The following is a description of a gene set: Human Gene Set: HP_ATROPHY_DEGENERATION_AFFECTING_THE_CENTRAL_NERVOUS_SYSTEM Atrophy/Degeneration affecting the central nervous system species: Homo sapiens, and this is the list of marker genes: TDP1, FKBP6, HERC1, ATP5F1E, NEUROD2, NEK1, KANK1, NFU1, TAF2, CLN6, ATP5PO (ATP synthase peripheral stalk subunit OSCP), SCN1A, ABCD4, GPKOW, SCN9A (NCBI Gene Id 93955), PGAP2, EMC1, FRMPD4, SCO2, GABBR2, METTL27, ECHS1, NOVA2, IKBKG, VPS11, CDH23, PLCB1, GABRD, GNPTAB, NDUFA11 (NCBI Gene Id 126328), POLR3K, RNU7-1 (RNA, U7 small nuclear 1), PPFIBP1, RTN2, SLC17A5, STXBP1, ATAD1, MT-ND1 (mitochondrially encoded NADH:ubiquinone oxidoreductase core subunit 1), RHOBTB2, SETX, DTYMK, NALCN, FGF12, EXOSC8, PDHA1, LHX1, SLC19A1, RMND1, DOCK7, PARS2, MED25, COQ9, POLG, CYB5A, UBA5, SUCLG1, LYST, DEGS1, PDE6D, SLC39A8, GET4, SPG7, TTC5, MOCS1, RFC2, VPS13A, PMPCA, SIGMAR1, DCDC2, OSTM1, DOCK6 (dedicator of cytokinesis 6), PCNA, TOMM40, ATP6AP2, PIGQ, YRDC, GFM2, TAF6, ZSWIM6, OPA1, COG7, NDE1 (nudE neurodevelopment protein 1), CYP27A1, WDR81, MT-CO3, GM2A, TBL2, KCNQ2, ATXN3, NFIX, STX1B, SERAC1, GAD1, TARS1, DPH5, FUCA1, BICRA, ALDH7A1, TBCK, RPS6KA3, ITPA, NDUFV1, CTCF, SLC35C1, PPP3CA, YWHAE, KARS1, KIF7, GCDH, PNKP, SLC33A1, SUMF1, DYNC1I2, CPLANE1 (NCBI Gene Id 84157), ITPR1, LIMK1, PIGT (phosphatidylinositol glycan anchor biosynthesis class T), CNPY3, NUP54, KIF26A, QARS1, ATP1A2, POMT1, BCS1L, SEPSECS, SLC39A4, GLE1, CCDC47, AGA, ERCC8, NAGA, ATN1, MVK, CTSF, GABRB2 (gamma-aminobutyric acid type A receptor subunit beta2), IRF2BPL, MRM2, LAGE3, SNCAIP, CASK, ST3GAL5, XPA, TIAM1, EHMT1, WIPI2, BTD, TRNT1, TECPR2, ADH1C, MECP2, CHAMP1, MMADHC, ACTG1, MAPT, NAXD, UFM1, GOT2, HID1, ALG3, ASAH1 (NCBI Gene Id 79795), ACTB, MARS2, GLYCTK, SORL1, EXOSC1 (NCBI Gene Id 51013), SHPK, MECR, PTDSS1, NTNG2, VPS33A, ATP13A2, ATP5F1A, CTNS, EIF4A2, MT-TT, USH1G, LMNB1, CACNA1A, GRN, ADK, NARS2, DPAGT1, ADAM22, SLC16A2, VAC14, KIF1C, SCN3A, MEF2C, MBTPS2, ELOVL4, DPM1, PIGN, AIFM1, HIC1, COQ4, MT-TL1, SLC32A1, CYLD, CYFIP2, OFD1, TBK1, VPS35, CDK19, KCNMA1, PHGDH, FOXP2, CWC27 (CWC27 spliceosome associated cyclophilin), SIK1, CFAP410, BRAF, KCNC2, VRK1, LIPT2, CCT5, ATP5F1D, GBA1, SON, DARS2, STAMBP, ATXN2, PCCB, ATP6V1A, SNCA, TBL1XR1, VPS41 (NCBI Gene Id 27072), ADGRV1, SLC5A6, NHLRC2, PUF60, PCLO, CLPB, EPG5, HNRNPA1, ALG14, MAP2K2, PMPCB, SUCLA2, PYCR2, RUSC2, TREX1 (NCBI Gene Id 82474), PFN1, ALS2, TRAF7, DHCR7, PRKDC, FUS, DPYD, C19orf12, TRAPPC11, TRMT5, PTCD3, SNF8, ACTL6B, MYO7A, UBQLN2, RFXAP, CARS2, GRID2, SLC35B2, AP4E1, GNAO1, RTEL1, PPP2R2B (NCBI Gene Id 56686), FARS2, MTHFR, RAD21, ADPRS (NCBI Gene Id 54936), NOTCH3, ERCC3, LRRK2, TCTN3, GALC, B3GLCT, VCP, NARS1, DNAJB4, REPS1, IDS, GRIA4, PIGU, MAF, PCK1, TIMM50, PAFAH1B1, TGFB1, SLC25A15, OPHN1, PDYN (prodynorphin), CASZ1, POLA1, ALG13, GRIA2, TUBGCP4, DNMT1, GNAQ, EXOSC5, FTO, SLC1A2, AP4S1, APOE, CIZ1, STAG1, COG2, VPS53, YWHAG, GRIN1, SMC3, COG4, IFT56, NMNAT1, FXN, MAP2K1, MORC2, IFIH1, NDUFV2, TBCD, NODAL, COQ2, FMR1, CACNA1I, PIGV, TMX2, SYNGAP1, ZNHIT3, AARS1, KCNA1, RAB23, POGZ, C9orf72, MAN2B1 (mannosidase alpha class 2B member 1), SNRPN, PRKAR1B, GNB1 (NCBI Gene Id 87729, G protein subunit beta 1), SLC39A14, TMEM270, L2HGDH, MT-ND4, AARS2, YME1L1, ATG7, USH1C, SMG9, TANGO2, KDM6A, TARS2, CBS, SYNE1, PUS7, PRKN, PRDX3, AHDC1, PSEN1 (presenilin 1), GTF2H5, WASHC5, CLN8, UQCRC1, PDE10A, CPSF3, CHMP2B, TPK1, POLR1A, GLUL, COASY, GABRA5, USP9X, MYO5A, PCCA, PPT1, KIDINS220, SAMHD1, LARGE1, MT-TW, NUS1, TMEM67, FDXR, CRLS1, AP3B2, PARN, APP, DNAJC3, FARSB, FADD, TYROBP (transmembrane immune signaling adaptor TYROBP), CLCN4, MT-ND5, NUP214, PQBP1, GABRG2, PUM1, ELOVL5, POLR3B, MRAP, EIF2B4, MT-CO2, MAG, GMPPB, RNASEH2A, POMT2, GTF2I, ADAT3, KIF1A, WARS2, PNPLA6, DNAJC6 (NCBI Gene Id 9829), SETBP1, FGFR3, EXOC7, ATPAF2, GRIN2A, MED17, TRAPPC9 (trafficking protein particle complex subunit 9), NRROS, NGLY1, NDUFA9, SLC25A46, PLA2G6, WWOX, GEMIN4, MT-ATP6, TBC1D24, NUTM2B-AS1, COL18A1, WHRN, ASNS (asparagine synthetase (glutamine-hydrolyzing)), ATP5MK, CLN5, MT-TF, TSEN15, TPP1, TRAPPC6B, PANK2, COX4I1, AP4B1, TMEM147, SLITRK2, AUH, FKRP, SPEN, EXOSC9, GON7, KCNQ5, UGP2, TREM2, CDKL5, COG1, ERCC1, NTRK2, TBP, SMN1, DHX30, EXOC8, SLC38A3 (NCBI Gene Id 10991), LRP12, DNAJC5, MMACHC, VPS16, HEXB, ADAR, PRNP, VPS4A, ACY1, PODXL, GLB1, PIGL, EXOSC2 (exosome component 2), NACC1, PEX1, OCA2, SKI, PCYT2, TTC19, PRDM16, TXN2, COG6 (component of oligomeric golgi complex 6), NAXE, STX1A, PCDH15, FA2H, SYT2, DHDDS, HTRA1, PDHX, FAR1, MYT1L, RNU4ATAC, TERT, CYB5R3, TARDBP, ABCD1, NUP133, ZNF668, LYRM7, UBAP1, MT-TH, TOE1 (target of EGR1, exonuclease), STUB1, DNM1L, MDH2, GABRA1, ATL1, NDUFAF5, MINPP1, HTT, ANG, DNM1, CHCHD10, PEX19, SOD1, EIF4G1, NDUFB8, SNX14, SPTBN1, TIMM8A, NAA10, DLAT, EMX2, KCNA2, JPH3, NBN (NCBI Gene Id 4683), GLT8D1, CNTNAP1, ATP1A3, PON3, PLAA, HNRNPA2B1, FH, PHACTR1, ERCC6, FTH1, OPTN (optineurin), HRAS, OTUD6B, WNK3, PCDHGC4 (protocadherin gamma subfamily C, 4), RBL2, KCNB1, FGF13 (fibroblast growth factor 13), AFG2A, OCLN, SMARCC2, PITRM1, NUP62, UNC80, PNPO, NEFL, ESPN, RERE, BRAT1, PIGS, NCF1, PON1, PLPBP, GBA2, ATXN7, SOX10, TSEN54, HSD17B10, BSCL2, IBA57, SLC12A5, AMPD2, SPG21, PIGP, OSGEP, B4GALNT1, TMEM106B, KCNAB2, NADK2, NAE1 (NCBI Gene Id 8883), CPLX1, ZFX, FBLN1, TRAPPC12, NDN, RNF113A, HDAC4, PRPH, CTDP1, HSD17B4, CNKSR2, RBM28, WDR73, ALG1 (NCBI Gene Id 56052), HSPG2, ALG11, SERPINI1, PRDX1, NDUFS2, TRRAP, UBA1, TINF2, GFAP, MT-ND6, RNU4-2, UCHL1, DIAPH1, PCDH19, GFM1 (NCBI Gene Id 85476), TK2, BRD4, TRIM8, SMN2, PRRT2, UBE3A, MPDU1, HEPACAM, NECAP1, SNORD118, ASPA, AP4M1, SZT2, GTF2E2, MOCS2, ESAM, CAD, H3-3A, MMP23B, RNASEH1, COX16, PIGA, ALG8, NIPBL (NCBI Gene Id 25836), FRRS1L, PRKCZ, NIPA1, YIF1B (Yip1 interacting factor homolog B, membrane trafficking protein), SLC25A22, DALRD3, SACS, CAPRIN1, OTUD5, ERCC5 (ERCC excision repair 5, endonuclease), SCN2A, SMC1A, AXIN1, DNAJC30, MTR, CAMTA1, EPM2A, HTRA2, NDUFS1 (NADH:ubiquinone oxidoreductase core subunit S1), ABHD5, WDR45, ATP6V0A1, FTL, POLG2, NANS, FLI1, SLC2A1, NDP, DMXL2, DCTN1, GRIN2D, GUF1, TRAK1, PSAP, AIMP1, ACO2 (aconitase 2), COX8A, KMT2D, CCNF, EPRS1, VAPB, BMP4, NHLRC1, KCNT1, CELF2, AP1B1, CPA6, ZNF592, KPNA3, PIGG, PLK4, ROGDI, UNC13A, CLN3, SLC9A6, SQSTM1, CARS1 (cysteinyl-tRNA synthetase 1), SNAPC4, PUS3, DNAJC13, ADARB1, SHQ1, TPI1, PACS2, SCN8A, BUB1, CEP126, RNU12, AFF3, SPG11, GUSB, TPRKB, AP1S2, CIB2, UBE4B, BCAS3, AP3D1, ARX, INTS11, LSM11, DAO, ALDH18A1, DHFR, TUBGCP6, TRIT1, CACNA1B, NEXMIF, UBTF, ALG9, ADA2, ATRX (NCBI Gene Id 6475), PEX7, NEFH, TMCO1, MT-TS2, SCO1, DNAJC19, SATB1, EXOSC3, EEF1A2, FOLR1, KIF5A, GTF2IRD2, ERCC4, MOGS, MTRR, IDUA, AIMP2, ZNF335, MAPK8IP3, FBXL4, ATXN1, NR4A2, CPT1C, FBXO28, NDUFA2, RNASEH2B, ERCC2, TAF15, CLTC, ABCA7, HECW2, USH2A, DDB2, BAZ1B, TUBA4A, ZBTB20, TP53RK, PI4KA, HDAC8, BCAP31, SIX3, KCNH5, DSE, ASL, DGUOK, PON2, NPC1, CTSD (cathepsin D), MPLKIP, SLC31A1, ATP8A2, COLGALT1, SBF1, COX11, FGFR1 (NCBI Gene Id 84151), MT-ATP8, KDM5A, ACBD6, FIG4 (NCBI Gene Id 9896), NDUFA8 (NCBI Gene Id 4702), MT-TQ, SPTLC1, TSEN2, CACNA1G, TMEM70, COG8, PSEN2, SCYL2, MYORG, ZC4H2 (NCBI Gene Id 7493), TRAPPC4, HIVEP2, DOHH, ATP11A, RARS2, SLC1A4, TWNK, IARS2, CSF1R, TRPM7, SYNJ1, ADSL, SPAST, KCTD7, MED11, ANXA11, HACE1, RARS1, HUWE1, GIGYF2, MGAT2, CLIP2, CDC42, GTF2IRD1, RFXANK (NCBI Gene Id 8625), COPB1, GJC2, NSD1, SPTAN1, PPARGC1A, IGHMBP2, RAB3GAP2, NT5C2, ADNP, LUZP1, COG5, APC2, ERBB4, LONP1, FASTKD2, XPC, RNF216, ELN, TBC1D20, PLP1, RNASEH2C, RAB18, AGTPBP1, CACNA1E, DMPK, PURA, CACNA2D1, RAB3GAP1, VPS37D, SLC35A2, RNF125, ATXN8OS, CERS1, EIF2AK2, BUD23, KY, HNF1B, MFSD8, EIF4H (NCBI Gene Id 94573), DKC1, GDAP2, FOXG1 (forkhead box G1), GRM7, GOLGA2, CNTNAP2, ACER3, PSPH, SLC2A3, VPS13C, GRIA3, DDX3X (DEAD-box helicase 3 X-linked), ZMIZ1, ACD (ACD shelterin complex subunit and telomerase recruitment factor), FZR1, MATR3, CYP7B1, TIA1, RTTN, KRAS, POLR3A, VARS1, CLP1, MUC1, MAGEL2, LIAS (NCBI Gene Id 94182), WFS1, NKX6-2, RFT1, MT-CO1, POU4F1, SMG8, CISD2, RALGAPA1, BICD2, SUOX, PDE8B, SLC13A5, TFG, GABRA2, TRAPPC2L, PDZD7, HCN1 (NCBI Gene Id 609), PDPN, DYRK1A, PGAP1, PRUNE1, MED27, SCN1B, PEX16